The following is a description of a gene set: from publication Chen Y, Wang X (PMID 31504780) Genes predicted to be targets of miRBase v22 microRNA mmu_miR_146a_3p in miRDB v6.0 with MirTarget v4 prediction scores > 80 (high confidence targets). Mouse Gene Set: MIR_146A_3P species: Mus musculus, and this is the list of marker genes: Ccny, Ehd3, Lypla1, Asap1, Plcl1, Fgr, Slc25a32, Arhgap6, Igf2bp2, Sult3a1 (sulfotransferase family 3A, member 1), Nsdhl, Khdc1b, Mtf1 (metal response element binding transcription factor 1), Epm2aip1, Rpl31, Il1rapl2, Epcip, Sema3a, Shroom2, Tafa2, Thsd7a, Ctdspl2, Acsl6, Col4a3, Mbd2, Acer3, Rtn4, F13a1, A1cf, Zfhx4, Arl8a, 1600012H06Rik, Fat4, Pcdh7, Serpini1 (serine (or cysteine) peptidase inhibitor, clade I, member 1), Amph, Tpst2 (protein-tyrosine sulfotransferase 2), Dgkg (diacylglycerol kinase, gamma), Txnl1, Atp8b1, Cbln4, Gmnc, Sspn, Inpp4b, Golga4, Dpy19l4, Cmklr1, Zfp868, Gbp7 (NCBI Gene Id 229900), Pcdh19, Lmbr1, Spn, Usp29, Stt3b, Rhobtb1, Icmt, Fstl4, Dlg2, Camsap2, Map2, Slc6a6, Sox11, Rprd1a, Rala, Ms4a1, Unc119b, Gal3st2, Trim52, Pdzrn3, Pex13, Sh3kbp1, Hspa12a, Atg12, B3gnt2, B4galt5, Man2a1, Yod1, Pus7l, Htr5a, Gdi1, Gal3st2c, Ywhab, Kcns1 (K+ voltage-gated channel, subfamily S, 1), Top1, Myo9a, Slc10a2, Tsc22d2, Acp1 (acid phosphatase 1, soluble), Klhl14, Zfp575, Tyr (NCBI Gene Id 22173), Wnk3, Ndel1, Uggt2, Steap2 (six transmembrane epithelial antigen of prostate 2), Nfatc1, Fam3c, Cyren, Csgalnact2, Uqcrfs1, Rras2 (NCBI Gene Id 97407), Ppm1b, Samd5, Slc25a4 (NCBI Gene Id 11739), Slc30a7, Cited2, 2610528J11Rik, Ppp2r1b, Dcaf7, Klrc1, Chst11, Minpp1, Nfib, Rab30, Tube1, Prkar1a, Taf3, Serf1 (NCBI Gene Id 20365)